Given this list of marker genes SSX4, TFE3, GATA1, WAS, SSX1, SSX2, here is a description of the gene set: from publication Myllykangas S, Himberg J, Böhling T, Nagy B, Hollmén J, Knuutila S (PMID 16751803) Human Gene Set: MYLLYKANGAS_AMPLIFICATION_HOT_SPOT_1 Amplification hot spot 1: colocolized fragile sites and cancer genes in the Xp22.3-p11.1 region. DNA copy number amplifications activate oncogenes and are hallmarks of nearly all advanced tumors. Amplified genes represent attractive targets for therapy, diagnostics and prognostics. To investigate DNA amplifications in different neoplasms, we performed a bibliomics survey using 838 published chromosomal comparative genomic hybridization studies and collected amplification data at chromosome band resolution from more than 4500 cases. Amplification profiles were determined for 73 distinct neoplasms. Neoplasms were clustered according to the amplification profiles, and frequently amplified chromosomal loci (amplification hot spots) were identified using computational modeling. To investigate the site specificity and mechanisms of gene amplifications, colocalization of amplification hot spots, cancer genes, fragile sites, virus integration sites and gene size cohorts were tested in a statistical framework. Amplification-based clustering demonstrated that cancers with similar etiology, cell-of-origin or topographical location have a tendency to obtain convergent amplification profiles. The identified amplification hot spots were colocalized with the known fragile sites, cancer genes and virus integration sites, but global statistical significance could not be ascertained. Large genes were significantly overrepresented on the fragile sites and the reported amplification hot spots. These findings indicate that amplifications are selected in the cancer tissue environment according to the qualitative traits and localization of cancer genes. species: Homo sapiens